Given this list of marker genes GART, AKR1B10, ABCC2, MCM3, ENO1, BCAM, LEPROTL1, SIAH2, ELMO2, PLEC, MPP1, AKR1C1, ATP2B4, MARS1, CHD4 (NCBI Gene Id 1108), RAB4A, SCHIP1, LYN, F3, BCL2L1, MICB, XKR8, ACIN1, HP1BP3, PGK1 (NCBI Gene Id 5230), FKBP1A, PRKCA, SAP30, CDCA8, HJURP, UBE2G1, IGFBP4, DELE1, SKP2, FHL1, STIP1, PABPC3, ALOX5AP, EPOR, BPNT2, KPNA2, GSPT1, MAZ, CIB2, GAPVD1 (GTPase activating protein and VPS9 domains 1), TPX2, SRRM1, TKT, CCT2, CENPA, MAN2A2 (NCBI Gene Id 55485), KIF20A, CEACAM6, CKLF, UBBP1, SNRPA1, GATC, G6PD, CCN2, KPNB1-DT, SUN1, PPP2R5D, KIR2DL5A, OSMR, CALM1, LRRC59, RPS17P5, TYMS, ETS2, EIF4G1, GCLM, AKR1C3, ASB9, PLIN3, ASCC1 (NCBI Gene Id 51008), KPNB1, NR2F2, PTBP1, HMGB3, UBFD1, here is a description of the gene set: At least one third of all cases of epithelial ovarian cancer are associated with the production of ascites, although its effect on tumor cell microenvironment remains poorly understood. This study addresses the effect of the heterologous acellular fraction of ovarian cancer-derived ascites on a cell line (OV-90) derived from the chemotherapy-naïve ovarian cancer patient. Ascites were assayed for their effect on cell invasion, growth, and spheroid formation. When compared to either no serum or 5% serum, ascites fell into one of two categories: stimulatory or inhibitory. RNA from OV-90 cells exposed to selected ascites were arrayed on an Affymetrix HG-U133A GeneChip. A supervised analysis identified a number of differentially expressed genes and quantitative polymerase chain reaction validation based on OV-90 cells exposed to 54 independent ascites demonstrated that stimulatory ascites affected the expression of ISGF3G, TRIB1, MKP1, RGS4, PLEC1, and MOSPD1 genes. In addition, TRIB1 expression was shown to independently correlate with prognosis when its expression was ascertained in an independent set of primary cultures established from ovarian ascites. The data support the validity of the strategy to uncover molecular events that are associated with tumor cell behavior and highlight the impact of ascites on the cellular and molecular parameters of ovarian cancer. from publication Puiffe ML, Le Page C, Filali-Mouhim A, Zietarska M, Ouellet V, Tonin PN, Chevrette M, Provencher DM, Mes-Masson AM (PMID 17971902) Genes up-regulated in OV-90 cells (ovarian cancer) exposed to ascites which inhibited invasion. studied in species Homo sapiens Human Gene Set: PUIFFE_INVASION_INHIBITED_BY_ASCITES_UP